Given this list of marker genes ATP5F1A, COX16, COX5A, SLC6A19, ALDH4A1, NDUFC2, ALDH18A1, CA5A, LIPT1 (NCBI Gene Id 51601), SLC6A18, PRODH, PDP1, SLC7A7, TEFM, TNFRSF11B, SLC6A20, TARS2 (NCBI Gene Id 80222), SLC36A2, NDUFB10, COX10, here is a description of the gene set: species: Homo sapiens Any deviation from the normal concentration of proline or a proline metabolite in the blood circulation. Abnormal circulating proline concentration Human Gene Set: HP_ABNORMAL_CIRCULATING_PROLINE_CONCENTRATION